Given this list of marker genes MORN4, VCF2, THY1, NF2, SLC25A37, TAF9B, MOB3B, CASTOR2, ZNF608, MYO15A, RAB9B, LIFR, SIRPB1, GYPE, PFKFB3, PGAM1, KIAA0930, VDR, TRAF6, BAIAP2 (BAR/IMD domain containing adaptor protein 2), ST8SIA2, SLC12A6, MAVS, ARHGAP1, DCAF10, DIP2B, MBOAT2, CFL2, PARD3B, POU4F1, PEA15, ANKS1B, CCDC80 (coiled-coil domain containing 80), JPH4, PCCB, GUF1, GRIP2, GPR153, ANKRD63, RHOA, NDUFB4, AMFR, HAPLN1, CTNNA3, ZNF592, SEMA3F, PITPNM2, NUCKS1, RETREG2, TEAD3, PACS2, PCBD2, VANGL1, CDK16, FAM120C, C2orf68, SSR1, STMN2, ETF1 (eukaryotic translation termination factor 1), CBFA2T2, PPFIA2, TNR, VGLL4, ADAMTSL4, SLC24A2, NFASC, NHSL1, BACH2, SLC25A45, HDGFL2 (HDGF like 2), ATP1B2, THEM5, SSH2, TENT4A, IRGQ, SUPT6H, RANBP10 (RAN binding protein 10), ZC4H2, YWHAQ, MOSPD3, NECTIN2, TRIO, HS3ST3B1, ZNF609, ZBTB21, ARF3, ESRRG, FAM227A, SLC12A5, AP1M2, TUB, MLEC, SH3PXD2B, USP9X, GABBR2, ICMT, ZBTB47, CCDC136, VCL, CFAP418, FHIT, ASPHD2, SNPH, C9orf152, PDZRN3, MAP3K9, NR4A3, CSF1, SLC24A3, CBX5, PDE3A, EI24, MACC1, CACNA1B, RANGAP1, IQCJ-SCHIP1, ABCC5, PIK3AP1, SCN4A, ATXN1, FBXL20, NR6A1, STEAP2 (NCBI Gene Id 50630), FSTL4, STX2, SOX6, MAPKBP1, ZDHHC9, XPO7, WIPF3, KCND2, CRELD1, LINGO1 (NCBI Gene Id 84894), CADM2, HMGN3, LHPP, RAB3C, HLF (NCBI Gene Id 3131), DEPTOR, CNOT2, CKMT2, SV2B, STARD3, KCNA1, EFNA1, PRKN, STIM1, RAB35, SCAMP2, TBL1Y, ZNF672, ANK1, NECTIN1, SYS1, RNF169, ETV6 (NCBI Gene Id 4348), SH2B3, NCOA4, TMCC1, KIF18B, GLG1, SLC43A2, SLC30A7, CD300LG, TOM1L2, COL5A3, ASXL1, TRIM33, SPOCK2, MAPK8IP1, PTPN12, PPM1M, NSD1, SLC4A7, PDXK, TMEM201, GARRE1 (granule associated Rac and RHOG effector 1), MFSD14B, COPS7B, CAMSAP2, YPEL1, HEATR1, here is a description of the gene set: Human Gene Set: MIR6893_5P from publication Chen Y, Wang X (PMID 31504780) studied in species Homo sapiens Genes predicted to be targets of miRBase v22 microRNA hsa-miR-6893-5p in miRDB v6.0 with MirTarget v4 prediction scores > 80 (high confidence targets).